Given this list of marker genes DAO, SNCA (NCBI Gene Id 6622), SLC6A3, TGFB2, GCH1, PARK7 (NCBI Gene Id 113880), TH, NT5DC2, ALDH2, GPR37, NR4A2, DDC (dopa decarboxylase), VPS35, here is a description of the gene set: The chemical reactions and pathways resulting in the formation of dopamine, a catecholamine neurotransmitter and a metabolic precursor of noradrenaline and adrenaline. species: Homo sapiens Human Gene Set: GOBP_DOPAMINE_BIOSYNTHETIC_PROCESS